Given this list of marker genes SOS1, SHC1, PLCG1, EGFR, UBB, HRAS, PIK3CA, HSP90AA1, RPS27A, PIK3R1, EGF, NRAS, CBL (Cbl proto-oncogene), UBC, GRB2, KRAS, CDC37, GAB1, UBA52 (ubiquitin A-52 residue ribosomal protein fusion product 1), here is a description of the gene set: Ligand-responsive EGFR cancer variants harbor mutations in the kinase domain or point mutations in the extracellular domain. These altered EGFR proteins are able to signal in the absence of ligands, but their ligand binding ability is preserved and downstream signaling is potentiated when ligand is available. Reactome Pathway: Signaling by Ligand-Responsive EGFR Variants in Cancer part of: Signaling by EGFR in Cancer species: Homo sapiens